Given this list of marker genes TNFSF11, CACNA1A, MYCN, KIF1B, TCIRG1, SLC35A2 (NCBI Gene Id 7355), SLC1A3, FRMD5, HACE1, GBA1, ALK, ATP1A2, ATP1A3, SLC6A3, PHOX2B, TMEM240, VPS13D, SNX10, LMO1, LIN28B, CLCN7, here is a description of the gene set: Human Gene Set: HP_SACCADIC_OSCILLATION An involuntary abnormality of fixation in which there is an abnormal saccade away from fixation followed by an immediate corrective saccade. Saccadic oscillation studied in species Homo sapiens